Given this list of marker genes Elp3 (NCBI Gene Id 74195), Elp4, Trmu, Nsun3, Trmt9b, Ctu2, Elp1, Urm1, Gtpbp3, Ctu1, Nat10, Dph3, Adat2, Kti12, Alkbh1, Mocs3, Elp2, Elp6, Mto1, Alkbh8, Elp5, here is a description of the gene set: The process in which the nucleotide at position 34 in the anticodon of a tRNA is post-transcriptionally modified. studied in species Mus musculus Mouse Gene Set: GOBP_TRNA_WOBBLE_BASE_MODIFICATION